The following is a description of a gene set: Enables the transfer of a lipid from one side of a membrane to the other. studied in species Mus musculus Mouse Gene Set: GOMF_LIPID_TRANSMEMBRANE_TRANSPORTER_ACTIVITY, and this is the list of marker genes: Slc22a19, Slco1a1, Slc27a5, Slc22a2, Slc27a6, Ceacam2, Abcb11, Slc22a7, Slco2a1, Slc10a3, Fabp4, Slc25a20, Slc22a28, Slco1a8, Slc5a8, Slco1c1, Slco1a4, Slc10a6, Slc22a27, Cd36, Mfsd2a, Slc51a, Slc27a4, Fabp3, Slc22a8, Slco1a5, Rbp4, Abcg4, Slc10a5, Abcd2, Slc22a6, Slco1a6, Slc43a3, Fabp2, Slc10a1, Slc10a4, Abcd4, Abcc1, Stra6, Slc27a1 (solute carrier family 27 (fatty acid transporter), member 1), Slc2a1, Slco4a1, Slc51b, Stra6l, Abcg1, Fabp1, Slc10a4-ps, Slco2b1, Fabp5, Slco1a7, Abcc3, Slc10a2, Slc22a26, Slc22a30, Abcd3, Slc22a29, Slc22a1, Slco3a1, Ceacam1, Slc27a2, Abcc4, Slco1b2, Slc10a7, Abcd1